The following is a description of a gene set: Mouse Gene Set: GOCC_TRAF2_GSTP1_COMPLEX studied in species Mus musculus A protein complex comprising tumor necrosis factor (TNF) receptor-associated factor 2 (TRAF2) and glutathione S-transferase pi 1 (GSTP1). This complex is thought to disrupt the TNF signaling cascade, thus down-regulating inflammatory responses., and this is the list of marker genes: Gstp2, Gstp-ps, Traf2, Gstp1, Gstp3